Given this list of marker genes SYNJ1, HOOK3, TBL1XR1, FMO5, HIPK3, LRCH2, PRDX1, DDX3X, GPN3 (GPN-loop GTPase 3), ZCCHC13, TNPO1, RNF111, MARCHF6, SYDE2, KCNC2, VEGFC, RAB10, RNF217, RAB2A (NCBI Gene Id 5862), CPNE8, HORMAD1, CBFB, EIF1B, CTDSPL2, SCAF11, DPH6 (NCBI Gene Id 89978), BHLHE22, CYP2C8 (NCBI Gene Id 1558, cytochrome P450 family 2 subfamily C member 8), EGR1, CYYR1, DTD2, AHDC1, KPNA6, RORA, TRIM24 (tripartite motif containing 24), MOB4, MAP4, CDH19, WEE1, TRIM62, ZNF711, CDK11A, CFAP418, FLRT3, PTTG1IP, CCNYL1, LARP4B, EBF1, SLC16A7, FEZF1, GOLM2, FMO2, SCOC (NCBI Gene Id 60592), PNISR, LGALSL, MAP4K2, KLF5, IPO5, C5orf63, CANX, TAF1A, FAM76B, OCA2, C11orf58, LRRC32, TAF2, RBL2, CEP43, TSPAN7, TMEM209, NFIB (NCBI Gene Id 4781), PRDM2, CCT5, INO80D, RBM24, POU4F2, CREBRF, APOBEC3A, SLC9C1, ZMYND11, NEDD4, GOLIM4, GPR85, BTAF1, GATB, MPRIP, SPOCK3, IPMK, TAFA2, KALRN, SYT4, RNF13, ATAD2, SRSF5, GPC6, ADAMTS6, SIAH1, ZNF572, DCTN6, FSD1L, DGKH, FZD4, TRIM5, HMGCR, ACER3, UBE2K, RGS4, BOLL, GNAI3, APC, WASF2, CDK19, NAB1, KRTAP4-11, EXOC1, NIPBL, RPTN, TRIM49C, MTX3, CHSY3, LRP1B, TMX3, AP1S3, CCDC140, CMTM8, VEGFA, ABCG2, SLC16A4, PPP4R3B, GAS1, DPH7, PIGK, NUMBL, KDR, AFF4, SESTD1, LNPK, TCF7L2, RIC1, PCYOX1, TMEM117, KLF3 (KLF transcription factor 3), PCDH19, DMD, GPBP1L1, CCDC85A, SUSD5, CMTM4 (CKLF like MARVEL transmembrane domain containing 4), MTDH, ATG14, FRG2, RAB29, PHF21B (PHD finger protein 21B), UBA6, ATL2, SOCS2, ZCCHC24, TMEM252, HEG1, ATP5MC2, DSG3, PBX3, DACH1, SCAI, XRCC4, KHDRBS2, APCS, NTNG2, GTF2A1, EFNA5, NUCKS1, PHF20L1, DENND1B, SMC2, ADD3, KCNJ3, ARPP19, CHIC2, ADAM10, SASS6, CYFIP2, DARS1, MBNL3, ZNF281, SF3A1, ZNF503, ITGAV (NCBI Gene Id 7449), BPNT2, VWC2, SENP7, NFIL3, KDELR2, CEP135, C3orf80, BPTF, KANK1, UBE4B, ACLY, CLCF1, MACF1, KRTAP4-8, SINHCAF, HSPH1, MITF, GTF2H1, ATP13A3, IKZF2, STK38L, FAM174A, RBM3, CAPZA2, UBE2E3, ZEB1, ZNF527, PATZ1, ZNF77, VKORC1L1, ARID2, MYF5, ABHD13, PNRC1, RABGAP1, MDM4, NRG1, ZMYND8 (zinc finger MYND-type containing 8), TRAPPC10, CCDC80, FBXO45, CPSF6, PARD6G, KCTD21, TADA2B, PRRX2, GAS2L3, NECTIN1, MEPE, ATXN1L, B4GALT6, TRIM49, EIF2S2, ZNF678, C11orf87, UBIAD1, GTF2F2 (general transcription factor IIF subunit 2), ARMC3, CILK1, NF1, FAM13C, EPB41L2, GNE, TOB2, ING2, NSD2, NCOA1, CHRNA9, RAI1, FRG2C, AEBP2, GRM3, UBE2E2, SAMD8, GPR162, PTPDC1, UBXN8 (NCBI Gene Id 7993), CLIC4, JMY, CASK, KCNJ13 (potassium inwardly rectifying channel subfamily J member 13), SPECC1L, PCDH7 (NCBI Gene Id 90855), FNIP1, SCAMP1 (secretory carrier membrane protein 1), ACSL4, C18orf32, TOB1, CEP350, HLA-G, ASCL1, PHTF2, CALU, SATB2, SRSF7, LMBR1, FRAS1, FAM168B, PDLIM5, ITGB1, BMS1, ADD1, HCN1, TYW5, EIF3A, BICC1, CCNG2, RGS7, MCTP1, CHIC1, EFR3A, ZNF492, ARID4B, SMAD5, CHN2, TMTC2, FCHSD2, CGGBP1, CPEB3, CDADC1, BCL2L11, METTL6 (methyltransferase 6, tRNA N3-cytidine), LNX1, BICD2, C8orf76, ROR1, SENP6, PLPP3, TMOD3, FNDC3B, EAF2, FGD4, FBXO30, SHPRH, TEX261, ZFAND5, PCDH18, UBN2, USP8, CERT1 (ceramide transporter 1), KCTD4, CDK2AP1, CSTA, AGFG1, PLCXD3, IL17A, CNR1, POU2F1, IFNW1, TSPAN19, CEBPB, STXBP5, SESN3, C2orf69, RPRD1A, ATAD5, FNBP4, RTN1, SBNO1, IL7, YIPF5, CCNK, TMEM263, USP43, FREM2, EP300, KLHL24, PACSIN3, LMO4, MINDY2, ZNF521, SLC33A1, STRN, SNRNP40, CAPRIN2, ANKRD13C, UBAP1, WLS, FRMD4A (FERM domain containing 4A), TLE4, HTR2C, SYCP2L, KLC1, ZNF107, CDK11B, SRF, CREBZF, MBTD1, WIPF1, DOCK9, SNRPB2, OCLN, BLTP3A, GNPAT, RNF44, CNOT6L, CFAP20DC, NAP1L1, RILPL2, KCTD1, FBXL3, CDK17, SNX29, NECTIN3, FOXC1, SSB, FZD6, GDI2, ZNF236, PTP4A1, MOB3B, SLC22A4, ZNF33A, APOBEC3B, HECTD2, ADM, NKRF, MAGI2, KIF20A, CAPZA1 (NCBI Gene Id 829), MBNL2, GMFB, SNAPC1, GXYLT1, RPS6KB1, SYT16, TVP23B, MAP2K4, TBX18, WDR72, FERMT2, TAOK1, BAAT, PRKD1, PRPF4, here is a description of the gene set: Genes predicted to be targets of miRBase v22 microRNA hsa-miR-374c-5p in miRDB v6.0 with MirTarget v4 prediction scores > 80 (high confidence targets). from publication Chen Y, Wang X (PMID 31504780) studied in species Homo sapiens Human Gene Set: MIR374C_5P